Given this list of marker genes SLC15A4, TAP2 (transporter 2, ATP binding cassette subfamily B member), SLC15A3, SLC15A1, SLC15A2, ABCB9, TAP1, here is a description of the gene set: Enables the transfer of a peptide from one side of a membrane to the other. Human Gene Set: GOMF_PEPTIDE_TRANSMEMBRANE_TRANSPORTER_ACTIVITY species: Homo sapiens